The following is a description of a gene set: Mouse Gene Set: GOBP_REGULATORY_NCRNA_PROCESSING species: Mus musculus A process leading to the generation of a functional regulatory non-coding RNA., and this is the list of marker genes: Tert, Ago2, Mov10l1, Piwil2, Fkbp6, Stat3, Pum1, Prkra, Tex15 (testis expressed gene 15 meiosis and synapsis associated), Trub1, Bcdin3d, Trp53, Snip1, Ddx4, Ago4, Parn, Tdrd6 (NCBI Gene Id 210510), Srrt, Mir361, ENSMUSG00000126352, Ago3, Bmp4, Exd1, Tdrd1, Pnldc1, Adar, Fbxo24, Ddx5, Il6, Tarbp2, Spout1, Tdrd7, Srsf3, Pld6, Pus10, Trim71, Ripk1, Zmpste24, Piwil4 (piwi-like RNA-mediated gene silencing 4, NCBI Gene Id 330890), Ncbp1, Nup155, Pum2, Mael, Zc3h7a, Ago1, Tdrd9, Lin28b, Tdrd12, Tgfb1 (NCBI Gene Id 21803), Drosha, Gpat2, Mettl3, Tsn, Piwil1, Dicer1, Henmt1, Rbm3, Tut4, Dgcr8, Hnrnpa2b1 (NCBI Gene Id 71605), Mecp2 (methyl CpG binding protein 2), Ddx3x, Lin28a, Tut7, Hnf1a, Zc3h10, Ncbp2, Gtsf1, Zc3h7b, Tsnax, Tdrkh